The following is a description of a gene set: Human Gene Set: GSE21927_C26GM_VS_4T1_TUMOR_MONOCYTE_BALBC_DN from publication Marigo I, Bosio E, Solito S, Mesa C, Fernandez A, Dolcetti L, Ugel S, Sonda N, Bicciato S, Falisi E, Calabrese F, Basso G, Zanovello P, Cozzi E, Mandruzzato S, Bronte V (PMID 20605485) Tumor growth is associated with a profound alteration of myelopoiesis, leading to recruitment of immunosuppressive cells known as myeloid-derived suppressor cells (MDSCs). Analyzing the cytokines affecting myelo-monocytic differentiation produced by various experimental tumors, we found that GM-CSF, G-CSF, and IL-6 allowed a rapid generation of MDSCs from precursors present in mouse and human bone marrow (BM). BM-MDSCs induced by GM-CSF+IL-6 possessed the highest tolerogenic activity, as revealed by the ability to impair the priming of IFN- -producing CD8+ T cells upon in vivo adoptive transfer. Moreover, adoptive transfer of syngeneic, GM-CSF+IL-6-conditioned MDSCs to diabetic mice transplanted with allogeneic pancreatic islets resulted in long term acceptance of the allograft and correction of the diabetic status. Cytokines inducing MDSCs acted on a common molecular pathway. Immunoregulatory activity of both tumor-induced and BM-derived MDSCs was entirely dependent on C/EBP transcription factor, a key component of the emergency myelopoiesis triggered by stress and inflammation. Adoptive transfer of tumor antigen-specific CD8+ T lymphocytes resulted in therapy of established tumors only in mice lacking C/EBP in myeloid compartment. These data unveil another link between inflammation and cancer and identify a novel molecular target to control tumor-induced immune suppression. We used gene expression analysis to identify those factors, secreted by tumor-infiltrating MDSC, which could drive emathopoiesis. Moreover we compare gene expression profile of tumor-induced MDSC, obtained from either the spleen and the tumor infiltrate of tumor bearing mice, and in vitro bone marrow-derived MDSC. studied in species Homo sapiens Genes down-regulated in CD11b+ cells from BALB/c mice bearing: C26GM colon carcinoma versus 4T1 mammary carcinoma., and this is the list of marker genes: MSL2, RPL27A (NCBI Gene Id 84736), LIPT1, JADE1, SNAP23, PMS2P2, BCL11B, PAFAH1B1, RNF125, TXNIP, UBE2H, PHC1, LYRM9, CBLB, PDE4C, DEFA4, ASB1, CREBBP, E2F3, TSC2, RPL18, PRKCZ, ANKRD36, MAML1, FCGR3B, MSL3, TUT4, NDRG1, SON, C11orf21, TAF1, RPL11 (NCBI Gene Id 6135), DICER1, P4HTM, ZNF839, LINC00623, HECTD4, AAK1, MPC1, IGBP1, S1PR4, IGFBP3, CD37 (NCBI Gene Id 951), TASOR, CMPK1, FRYL, SNRK, ELF1, NKTR, ZFAND3, USP47, PTCH1, ZNF137P, INTS8, BEX3, NR2C1, ATP6AP2, FOXN3, ITGA4, USPL1, TMEM260, EGLN2, ZFAND6, CYLD, ARL6IP5, CCNL1, TTC3, ZNF83, ZNF611, LY9, ZFC3H1, PTPN18, ARHGAP15, GMIP, SLC35E2A, SNX29P2, PLEKHF2, POLR1B, PCNX2, PPM1B, IFNGR2, MACF1, JRK, GCC2, ZNF500, FBXO9, ARHGEF1, ZNF394, VNN2, CD3E, ATP6V1G1, PRR11, MAT2B, GALNT11, PGPEP1, MAPK14, TMEM80, METTL9, TOB1, CNN2, STAT4, KLF12, ATRX, RNPEPL1, ABR, ZNF862, IDUA, CASC3, NOTCH2NLA, CD6, PNISR, MKKS, SPTAN1, GLRX, CCSER2, TRIM52, TTC17, EPB41, ZNF32, CDK11A, CRYL1, MAN2A2, WWP1, PAN2, ARL2BP, SETD1B, KLF13, EVI2A, YPEL5, TMED10, PLEKHA1, RPL10L, WBP1L, MPHOSPH8, DPEP2, MSL1, ACAP1 (NCBI Gene Id 9744), ZHX2, WASF2, TMEM41B, MXI1, CLK4, NACA, SLC9A8, RPL36AL, VEZF1, MPPE1 (NCBI Gene Id 65258), WSB1, RBL2 (RB transcriptional corepressor like 2), SCAF11, DLG1, OXLD1 (NCBI Gene Id 339229, oxidoreductase like domain containing 1), GABARAP, AKAP13, CITED2, CBFA2T2, GUSBP3, PABPC1, PBX2, PIK3CA, EIF3G, CCNG1, ADD3, S100PBP, EFNA1, HLA-F-AS1, ZFP36L1, VAMP4, TRAPPC8, TSC22D1, MAN1A2, CCNL2, ABI1, STK17A, RSRP1, CLASP1, DPM3, STAG3L1, PLEKHO1, ECHDC2, EFHC1, GATAD1, ARHGEF6, ATP8A1, CES2 (carboxylesterase 2), SRSF11, NLRP1, DPP8, PIGC, TNFRSF1A, PITPNC1, BAZ2A, TES, APBB1IP, CCDC28A, EVL, SYNE1, PMS2P3, GMFG